The following is a description of a gene set: Genes predicted to be targets of miRBase v22 microRNA hsa-miR-6779-5p in miRDB v6.0 with MirTarget v4 prediction scores > 80 (high confidence targets). species: Homo sapiens from publication Chen Y, Wang X (PMID 31504780) Human Gene Set: MIR6779_5P, and this is the list of marker genes: GCFC2, CALCR, MS4A1, IGF2BP1, ERBB3, NOVA2, COL11A2, MDM4, PACS1, CYP1A2, GLS, SLC8A1, CGNL1, RBMS2, MYO10, ITLN1, PIGK, CD164, SHOX, LYZL2, ATXN1, CORO2B, GFAP, FAM72A, ZFHX2, TCTN2, PSMB2, ZNF554, OSBPL1A, SULT1E1, HOOK3, ORAI2, LRRC51, ARID2 (AT-rich interaction domain 2, NCBI Gene Id 57676), GNAT1, CDH1, FAM72B, ACADSB, FOXP4, CTDSPL, EFCAB2, ZDHHC15, MRPS2, SAMD4A, MIP, CCDC28A-AS1, F2RL2, GFRA4, NID1, MAVS, DMRT1, GDI1, DCTN5, MASP1, ACKR2, CPSF7, PI3, IKZF3, CASTOR2, PYGO1, CDADC1, SCGN, CHTF8, ATP7B, SUSD5, CTSW, DAB2IP, MTCL2, SYBU (syntabulin), DEPDC5, CEBPZOS, SV2C, CDK8, ZNF655, PDE7A, COL27A1, LZTS3, RRP15, SLC6A11, PAPOLG, PRND, CASP10, MUCL3, LHPP (phospholysine phosphohistidine inorganic pyrophosphate phosphatase), SHISA6, ZNF793, EOGT, RAD51B, FUS, YWHAQ, ESYT1, SBSPON, PHACTR4, RALB, VPS25, UPK2, ZNF544, DTX4, ANKS4B, TIAM1-AS1, VIRMA, GLG1, PRICKLE3, NMNAT2, RRP7A, NCEH1, APELA, APOBEC3F, SH3BP2, HCFC1, TMEM239, TMTC1, MAPK13, SETD7, ASPG, RBM19, FBXL20, GNPNAT1, RAB21, PNMA2, ZNF674, CCL28 (C-C motif chemokine ligand 28), ELK1, CYP2B6, TMEM265, SYP (synaptophysin), ATP1B4, ARGFX, NSL1, PARP9, SYNGR1, CBX5, SLC2A4, CSF3R, MTFMT, SCAI, GAB2, HRH2, HUNK, FOXK1, STX5, ODAPH, PYCR3, GPR83, BMAL2, RIMS3, TMEM63C, MARK4, MTX3, EBAG9, RPL15, POLR2D, CYP20A1, NOL9, DDX6, MYORG, ZNF286B, PLEKHA5, TMEM132E, IRGQ, ZNF587 (NCBI Gene Id 84914), ZNF814, ZNF432, MS4A10, DNAJC8, TRAF3IP2, GFOD2, GNL3L, MTR, ZNF490, ARNT2, EEF2K, RHOJ, DYDC2, PLCXD1, VPS13B, FIBCD1, SHISA7, NDST1, PPP1R11, FBXL18, APOL6, KCNIP1, LYZL1